Given this list of marker genes EFNB2 (NCBI Gene Id 1948), FLT1, ANXA1, RNASE2, CCR4, CAMK1D (calcium/calmodulin dependent protein kinase ID), LSP1, PLXNA4, RAB13, FPR1 (NCBI Gene Id 2357), CSF1R, YTHDF1, UNC5C, CXCR1, MIR424, ZNF580, NR4A1, SLIT2, SEMA3A, F3, ECSCR, PDGFB, SPN, CXCR6, CASR, CCL24, OPN4, MIR34A, CCL4, CCL16, DEFB110, FOLR2, SEMA3D, EPHA2, HRG, DEFB114, CSF1, MET, CHGA, PLXNB3, ITGB3 (integrin subunit beta 3), PDGFRA, EDNRB, XCL1 (NCBI Gene Id 92337), CYP19A1, EDN2, VEGFD, CRKL, THBS4, IL16, MAPK3, C3AR1, TNFAIP6, STK39, TNFSF14, SEMA3E, PDGFRB, FCER1G, MIF, POU4F2, ENPP2, ARHGEF16, RALA, CCL25, SUCNR1, CXCL3, MAPK14, C5AR2, L1CAM (L1 cell adhesion molecule), CCL1, WNT7B, EPHB1, PLD1, NUP85, CD74, CXCL5, NTN1, EGR3, ACKR4, RHOG, CCR6, ANGPT2, TMEM102, FPR3, WNT3, SEMA4B, DUSP3, LECT2, TMSB4X, CXCL12, CXCL2, CALCA, CORO1A, SLAMF1 (NCBI Gene Id 6504), PIP5K1C, TUBB2B, CMTM3, CCR7, ABCC1 (ATP binding cassette subfamily C member 1 (ABCC1 blood group)), CXCL9, SEMA6D, CORO1B, CCL13, DPP4, ITGB2, ANO6, FLRT3, ROBO2, TGFB2, PGF, SEMA7A, DEFB133, PIK3CD, ALOX5, PTK2, NBL1, AIF1, SCG2, SLAMF8, ADAM10, JAM3, NRP1, DEFB109B, KLRC4-KLRK1, CCL15, PLGRKT, GPNMB, ROBO1, VEGFA, CYP7B1, NCKAP1L, ADAM17, HMGB1 (high mobility group box 1), ROBO3, SCRIB, PIP5K1A, DEFB103B, PLEC, MSTN, WNT5A, CCR1, OXSR1, USP14, DPEP1, CDH13, ADGRE2, PF4, RIPOR2, MDK, SRP54, SEMA3F, SMOC2, HSD3B7, FGF8, DEFB1, TAFA4, CCL26, CYRIB, PLA2G7, ENG, MIR16-1, TNFSF11, CCR3, SAA1, SEMA4D (semaphorin 4D), TRPM2, CCL20, GSTP1, SEMA3C, P2RX4, LBP, RAC2, BMP4, MEGF8, PRKCD, THBS1, ARRB2 (arrestin beta 2), IL1B, CX3CL1, CCL17, IL17RC, VAV1, LGALS3, ITGA2, CCL19, CXCR2, ADGRA2, TBR1, HSPB1, HRAS, S100A8, SEMA4A, PRKD2, CCL28, MIR149, DEFB130A, DEFB104A, DEFB4A, DSCAM, CCL3L3, RAC1, FGF4, CCR8, TNFRSF11A, NRG3, SWAP70, PTK2B, CCL11, IL12A, PF4V1, SEMA4G, MYCBP2 (MYC binding protein 2), PTGDR2, CXCR3, PDGFA, TSC2, PTPN2, CTSG, ITGA9, FGF1, HMGB2, PLAUR, CXCL14, ARHGEF5, OR10J5, KDR, PLA2G6, IL6R, EFNA5, CRK, HGF, PIK3CG, APOA1, CXCL17, RNASE3, LYN, TNFSF18, ITGA1, C1QBP, ELMO2, MAP2K1, WNT3A, NRG1, ANGPT1, AZU1, GPR183, FOSL1, SEMA4F, CALR, LGR6, RPL13A, ARTN, C5, DAPK2, LOX, TRPV4, PIK3C2G, RHOA, P2RY12, PPBP, CMTM2, CCN3, AGTR1, BMPR2, LEF1, WNK1, SEMA6C, CKLF, PLP2, CREB1, VEGFB, CCRL2, CYSLTR1, CCL3, FEZF2, SYK, VEGFC, VCAM1, CCL23, SEMA3B, PERP, SERPINE1, AKIRIN1, TYMP (NCBI Gene Id 4334), ANOS1, SEMA6B, PLAU, PREX1, DOCK4, CCN1, DEFB130B (defensin beta 130B), MTUS1, MCU, GPR15LG, DOCK2, GREM1 (gremlin 1, DAN family BMP antagonist), GAS6, CCL27, DEFB103A, CXCL6, RPS19, NOVA2, CCL4L2, NTRK3, CCR2, PRKD1, FER, CCL2, PDGFD, ACKR3, HDAC6, SEMA6A, IL6, S100A4, CXCL1, CXCL16, CCL22, PIKFYVE, RALBP1, SFTPD, DEFB131A, CSF3R, SPI1, CREB3, MMP2, IL10, CMTM1, S100A12, DEFA4, FFAR2, PLXNA3, BCAR1, FGF16, GDNF, MACO1, AMOT, TRPM4, GBF1, EDN1, TIRAP, PIK3CB, CXCR5, GAB1, TGFB1 (NCBI Gene Id 7040), SEMA3G, ACKR2, MIR223, BST1, KIF21A, CCL5, XCR1, NRP2, S1PR1, BSG, DUSP1, FLRT2, SLIT1, AGER, F7, CTTN, SMAD3, CD300H (CD300H molecule (gene/pseudogene)), OR1D2, JAML, DEFA1, CXCL11, KIT, ADAM8, GPSM3, FPR2, ITGAV, PADI2, IL17RA, PLEKHG5, MMP28, PTN, IL34, LTB4R2, CXCL8, NEDD9, LYST, DEFB104B, F2RL1, PPIB, CCL18, CCL21, MICOS10-NBL1, PTPRO (protein tyrosine phosphatase receptor type O), PTAFR, SERPIND1, FGF18, RAC3, XCL2, RARRES2, NINJ1, C5AR1, IL23A, SEMA5A, CXADR, STAP1, TREM1, NTF3, DDT, PRKCQ, NOTCH1, CMTM5, S100A9, CMTM7, MOSPD2, PARVA, SLC12A2, ELANE, CXCL10, EDN3, MIR15A, DNM1L, CCR10, FES, CMKLR1, PLA2G1B, CXCR4, ATOH7, CH25H, SLC8B1 (solute carrier family 8 member B1), RHO, CMTM8, FGF2, BIN2, LGALS9, STX3 (syntaxin 3), FGFR1, HOXB9, PDE4B, PROK2, ALKBH1, KLRK1, CCR9, HBEGF, CCL8, CXCL13, EPHA7, MAPK1, SLIT3, VAV3, LPAR1, PPM1F, MSMP, PPIA, COLEC10, RIN3, CCR5, SEMA5B, CCL7, TPBG, S100A14, FGF7, RYK, GPR18, CX3CR1, DEFA1B, APP, LGMN, FGF10, S100A7, SBDS, SEMA4C, TREM2, MPP1, PTPRJ, STX4, DEFB124, CNR2, CCL14, here is a description of the gene set: The directed movement of a motile cell or organism in response to an external stimulus. species: Homo sapiens Human Gene Set: GOBP_TAXIS